The following is a description of a gene set: Any process that alters the size or shape of an auditory receptor cell. studied in species Homo sapiens Human Gene Set: GOBP_AUDITORY_RECEPTOR_CELL_MORPHOGENESIS, and this is the list of marker genes: TPRN, CLRN2, PDZD7, PLS1, TECTA, CLRN1, SEC24B, STRC, REST, SOD1, GRXCR1, WDPCP, GRXCR2, ANKRD24, RAC1, CDH23, SCRIB, NHERF1, SLITRK6, MYO7A, USH1C, TRIOBP, WHRN, LHFPL5